Given this list of marker genes Msx1, Notch1, Msx2, Mks1, Alpk2, Galnt11, here is a description of the gene set: species: Mus musculus The series of molecular signals initiated by a ligand the binding to its receptor on the surface of a cell, which contributes to the progression of the heart over time. Mouse Gene Set: GOBP_CELL_SURFACE_RECEPTOR_SIGNALING_PATHWAY_INVOLVED_IN_HEART_DEVELOPMENT